The following is a description of a gene set: from publication Agarwal P, Raghavan A, Nandiwada SL, Curtsinger JM, Bohjanen PR, Mueller DL, Mescher MF (PMID 19592655) Genes down-regulated in comparison of CD8 T cells at 0 h versus those at 24 h. studied in species Homo sapiens Differentiation of naive CD8 T cells into cytotoxic effector cells requires three distinct signals- antigen (signal 1), costimulation -B7-1 (signal 2) and cytokine, either interleukin-12 or interferon-a/b (signal 3). Interaction of naive CD8 T cells with antigen and B7-1 programs cell division and proliferation whereas the presence of cytokines- IL-12 or IFNa/b promote survival, differentiation and memory establishment. In the absence of signal 3, the cells interacting with antigen/B7-1 undergo tolerance induction. The objective of this study was to elucidate the mechanisms how the provision of signal 3 promotes differentiation and averts tolerance induction in CD8 T cells. Trichostatin A is a pharmacological agent that inhibits histone deacetylase activity, hence regulating chromatin structure and gene expression and differentiation in many cell types. Gene signature profiles of IL-12, IFNa/b and trichostatin A stimulated cells were compared to elucidate the molecular mechanisms of gene regulation. Oligonucleotide microarray analysis is carried out to determine the extent and molecular nature of the CD8 T cell differentiation program induced by IL-12 or IFNa/b in concert with antigen and B7-1 signal. Human Gene Set: GSE15930_NAIVE_VS_24H_IN_VITRO_STIM_CD8_TCELL_DN, and this is the list of marker genes: TIMM9, MAD2L1, RFC4, TAF11, AIMP2, RNASEH2B, CKAP2, DDX1, SPR, TMEM97, PEX19, DDX41, TIMM8A, MRPL45, GFM1, CD200, RHOT1, INO80E, ENOPH1, RC3H2, KIF23, RPL7L1, DECR1, CARS1, PPA1, KGD4, LMNB1, CDC20, NUP85, CTPS1, CENPK, TNF, PIGF, BRCA1, NDUFS6, DUSP12, HASPIN, EMC8, LUC7L3 (LUC7 like 3 pre-mRNA splicing factor), PDAP1, CCT3, POLR3K, MRPL17, RCC1, CRCP, RAD50, DTD2, XCL1, CINP, ANLN, HAX1 (HCLS1 associated protein X-1), THAP7, ESF1 (ESF1 nucleolar pre-rRNA processing protein homolog), POLR2F, TSPAN31, SRM, MCM5, MRPS22, TGDS, ARMC1, NDUFS5, TRIP13 (NCBI Gene Id 9319), RFC2, POMP, BIRC5, SLC19A1, ERG28, PREP, SAAL1, CHCHD10, LGALS3, NOP2, ZDHHC16, CISD1, PDCD2, CYB5B, POLR1A, SOD2 (NCBI Gene Id 79099), CDKN2AIPNL, GCSH, CBX1, ARL2, NUDT19, CLIC4, TPD52L2 (TPD52 like 2), TAMM41, MRPL2, MTX2, RPF2, ELOC, MRPL37, NBN, RBPJ, SERPINB9, PDS5B, MRPS10, CARM1, PDIA4, TACC3, DHCR24, RRM1, SYNGR2, PLP2, RPRD1B, MNS1, PAFAH1B2, DCTPP1 (dCTP pyrophosphatase 1), CCT6A, ACOT7, TPI1, HRAS, HDHD2, CYP51A1 (cytochrome P450 family 51 subfamily A member 1), FKBP2, JMJD6, POLR2L, XPOT, DDX52, RRP9, IFT27, NDUFAF4, POLD2, ELOF1, DCK, IL2RA, HK2, GTF2H4, JAGN1, LSM2, CAD, GCLM, IDI1, PGAM1, PRIM2, CNPY2, MSMO1, MTMR9, RPN1, CSF2, CRTAP, CHERP, ABCD3, ALDH18A1, MRPL18, NME4, EZH2, CDK1 (cyclin dependent kinase 1), GMNN, RAD51AP1, COMT, BLMH, MTHFD2, RPA3, NOCT, DHCR7, PLK4, RCN2, GALK1, IRF4, MRTO4, OLA1, WDR77, PTGER4, LIG1, CSNK2A2, TUBG1, POLD3, GZMB, NCBP2, COQ5, RFC5, MOGS, FAM162A, NUDT1 (NCBI Gene Id 4521), PSMD12, RRP1B, TOP2A, PHTF2, IFI30, MKI67, ACAD9, RIOX2, CKS1B, PSPH, NUSAP1, NVL, RBM10, HMBS, WDR43, SIVA1, CKAP5, MCM2, TRIM37, IRF8, HAUS4, GIT1, ORC6, GTF2E2, TNFRSF9